The following is a description of a gene set: species: Mus musculus Mouse Gene Set: GOCC_GOLGI_ASSOCIATED_VESICLE_MEMBRANE The lipid bilayer surrounding a vesicle associated with the Golgi apparatus., and this is the list of marker genes: Tmed2, Tmed3, Furin, Copb2, Sppl3, Synrg, Ap1s1 (NCBI Gene Id 11769), Copa, Itm2b, Sppl2c, Golga5, Cltc, Sppl2b, Ap4b1, Ap1m2, Copg1, Arcn1, Sppl2a, Ap1s3, Pi4ka, Copz1, Ap1b1, Cltb, Cope, Zdhhc13, Copb1, Zdhhc17, Nrgn, Ap1g1 (NCBI Gene Id 52301), Kdelr2, Dipk2a, Aftph (NCBI Gene Id 75762), Kdelr1, Ap1s2, Gpr89, Copg2, Scyl1, Slc18a3, Clta, Clba1, Tmem199, Rassf9, Kdelr3, Copz2, Cspg5, Ap1g2, Ap1m1